Given this list of marker genes SLC26A2, SLC39A13, ACAN, TBX4, GNPTG, KIF22, COL9A1, CCN6, TRPS1, TRPV4, UFSP2, COL2A1, TONSL, here is a description of the gene set: studied in species Homo sapiens Flattened femoral epiphysis An abnormal flattening of an epiphysis of femur. Human Gene Set: HP_FLATTENED_FEMORAL_EPIPHYSIS